Given this list of marker genes IDO2, NADSYN1, ACMSD, HAAO (3-hydroxyanthranilate 3,4-dioxygenase), IDO1, KYNU, KMO, AFMID, here is a description of the gene set: species: Homo sapiens The chemical reactions and pathways resulting in the formation of nicotinamide adenine dinucleotide (NAD+), beginning with the catabolism of L-tryptophan into the precursor quinolinate. NAD+ is a coenzyme that interconverts with its reduced form, NADH, in many redox and catabolic reactions. Human Gene Set: GOBP_DE_NOVO_NAD_BIOSYNTHETIC_PROCESS_FROM_L_TRYPTOPHAN